Given this list of marker genes Itga6, Igfbp4, Lrp2, Igfbp1, Igfbp2, Igfbp6, Igfbp5, Insr, Igf1r, Itgb4, Itgb3, Igfbp3, Itgav, here is a description of the gene set: species: Mus musculus Binding to insulin-like growth factor I. Mouse Gene Set: GOMF_INSULIN_LIKE_GROWTH_FACTOR_I_BINDING